The following is a description of a gene set: Any process that modulates the rate, frequency, or extent of the multiplication or reproduction of osteoclasts, resulting in the expansion of an osteoclast cell population. studied in species Mus musculus Mouse Gene Set: GOBP_REGULATION_OF_OSTEOCLAST_PROLIFERATION, and this is the list of marker genes: Nmbr, Pth, Nmb, Ocstamp, Grem1, Gsk3b, Phf7, Flt3l